The following is a description of a gene set: An abnormal dilatation of the fourth cerebral ventricle. Dilated fourth ventricle species: Homo sapiens Human Gene Set: HP_DILATED_FOURTH_VENTRICLE, and this is the list of marker genes: MEF2C, WASHC5, NRAS, LAMA1, DENND5A, TMEM67, TUBG1 (NCBI Gene Id 7283), PGAP2, ASXL1, CEP57, TCTN3, ATXN1 (ataxin 1), TMEM237, RAC1, SEMA3E, LARGE1, FKTN, GJB6, EBP, CCDC22, HYLS1, TMEM138, GJB2, RNU12, FGFR1, NIPA1, CDC42, MID1, BCOR, DPF2, BLTP1, INTS11, PPP1CB, CEP290, CRPPA, GPC4, GMPPB, NIPA2, KRAS, SMARCC2, FTO, TMEM231, ARID1B, TUBA1A, PLCH1, SMARCD1, ARID2, WDR73, FLVCR2, EVC2, GRM1, DPH1, IGF2, COG8, POLR3A, RXYLT1, VPS51, MAGEL2, TRIP13, TMEM216, PIGN, TUBB, BUB3, POMK, BUB1, GPC3, ATP6V1E1, ASNS, POMT2, MKS1, DYNC2H1, DPH2, POLR1A, CC2D2A, MRE11, RPGRIP1L, RPGRIP1, CASK, KIF21A (kinesin family member 21A), POMGNT2, SMARCE1, CPT2, MAB21L1, AFF3, CDKN1C, WLS, MTM1, POMGNT1, MYOD1, RNF113A, TMEM107, SMARCB1, PLG, ESCO2, EVC, MUSK, B4GAT1, POGZ, VPS35L, SLC18A3, KCNQ1OT1, TCTN1, ATP6V1A, WARS2, CLXN, COX20, B9D1 (B9 domain containing 1), AP1S2, ZIC1 (NCBI Gene Id 7545), IFT80, FAR1, DOK7, GLI3 (NCBI Gene Id 2737), SOX11, PMPCA, KCNQ1, CHD7, ATP6V1B2, USP9X, EXOC2, B4GALT1, PUM1, SMARCA4, FKRP, B9D2, TBC1D24, PMM2, PHGDH, NPHP3, WDR35 (WD repeat domain 35), HRAS, ARMC9, ATP6V0A2, COL4A1, ARID1A, ATXN2, DYNC2I1, CSF1R, DYNC2I2, MAPKAPK5, TXNDC15, DDX3X, SLC35A2, SMG9, KIF5A, PIEZO2, BUB1B, DPYSL5, ALG3, B3GALNT2, CEP120, C2CD3 (NCBI Gene Id 26005), RAPSN, TCTN2, ATXN3, NUP88, DAG1, SOX4, WDR81, DHCR7, CSPP1, KIAA0586, OFD1, POMT1, KIF7, GTPBP2